The following is a description of a gene set: The appearance of immunoglobulin due to biosynthesis or secretion following a cellular stimulus, resulting in an increase in its intracellular or extracellular levels. Mouse Gene Set: GOBP_IMMUNOGLOBULIN_PRODUCTION species: Mus musculus, and this is the list of marker genes: Cd86, Nhej1, Polq, Ccr6 (NCBI Gene Id 12458), Fam210b, Tlr9 (NCBI Gene Id 81897), Cd40, Icosl, Card11, Itm2a, Shld3, Il2, Pagr1a, Tnf, Pkn1, BC037156, Foxp1, Il13, Tmbim6 (transmembrane BAX inhibitor motif containing 6), Fgl2, Phb1, Zpbp2, Phb2, Mir181b-2, Aicda, Supt6, Mcm3ap, Xrcc4, Msh2 (mutS homolog 2), Il6, Stat6 (signal transducer and activator of transcription 6), Tbx21, Lilrb4a, Nipal3, Sanbr, Ndfip1, Tcirg1, Stx4a, Parp3, Il5, Atm, Shld2, Tnfaip3, Ighe, Il13ra1, Tgfb1, Traf3ip2, Ighm, Il21, Ptprc, Yy1, Trex1, Mir181b-1, Paxip1, Vpreb1a, Exo1, Cd40lg, Exosc6, Mzb1, Trp53bp1, Il7r, Il4ra, Mir150, Dnajb9, Cgas, Nod2, Clcf1, Pcyt1a (NCBI Gene Id 13026), Siglecg, Pou2f2, Xcl1, Nsd2, Polm, Il2rg (NCBI Gene Id 16186), Ighd (immunoglobulin heavy constant delta), Tfrc, Ctnnbl1, Tnfsf13, Il33, Ighg1, Cyren, Rnf8, Rif1, Tnfsf13b, H2-T23, Nuggc, Ephb2, Fas (NCBI Gene Id 14102), Polb, Ezh2, Hmces, Fbn1, Aplf, Ifnb1, Nbn, Cd28, Hspd1, Prkdc, Tnfsf4, Il10 (interleukin 10), Xbp1, Lax1, Hpx, Crlf2, Pms2, Atad5, 6030468B19Rik, Msh6, Slc15a4, Lig4, Traf2, Samhd1, Fcgr2b, Galnt2, Kmt5b, Cd37, Shld1, Msh3, Gapt, Ung, Cd22, Vpreb3, Il4, Rbp4, Enpp1, Rnf168, Tcf3, Batf, Cd27, Foxp3, Kmt5c, Btk, Traf6, Bcl6, Gcnt3, Tnfrsf4, Il27ra, Swap70, Nfkbiz, Gpi1, Il13ra2, Sash3, Mad2l2, Exosc3, Ifng, Mlh1, Ercc1